The following is a description of a gene set: studied in species Mus musculus A MAPK cascade containing at least the ERK1 or ERK2 MAP kinases. It starts with the activation of a MAP3K, and the consecutive activation of a MPK2K and of ERK1 or ERK2. The cascade can also contain an additional tier: the upstream MAP4K. The kinases in each tier phosphorylate and activate the kinase in the downstream tier. The ERK1/ERK2 cascade is activated by mitogens, growth factors, G protein-coupled receptors, and results in cellular responses such as cell proliferation, cell differentiation and development. Mouse Gene Set: GOBP_ERK1_AND_ERK2_CASCADE, and this is the list of marker genes: Rasgrp1, Ptger4, Ccl19, Prkd2, Fpr2, Fbln1, Atp6v0c, Nrp1, Dab2ip, Dusp29, Havcr2, Nek10, Rap1b, Fgf1, Oxtr, Fpr-rs7, Epha7, Oprm1, Ednra, Epha2, Rgs14, Bmyc, Fpr-rs4, Tlr2, Itgb1bp1, Ccl19-ps3 (NCBI Gene Id 65959), Il1a, Pkhd1, Ext1, Dcc, App, Ntsr2, Itgav, Adora2a, Ptpn2, Ezr, Serpinf2, Abca7, Lmo3, Ripk2, Egf, Thpo, Fgfr2, Fgb, Dusp10, Zdhhc17, Xbp1, Gnai2, Nqo2, Dusp4, Ccl19-ps6, Fga, Hmgb1, Eif3a, Garem1, Ackr3, Apoe, Il6, Gpr183, Dbndd2, Tiam1, Ngf, Ccl21d, Adipoq, Grb10, Bmp2, Chrna9, Gstp3, Gcg, Cckbr, Ccn1, Tff2, Cnksr3, Ephb1, Dusp3, Ceacam1, Btn2a2, Rap1a, Dennd2b, Cav1, Ccl21e, Emilin1, Fermt2, Pten, Edn1 (endothelin 1), Bmper, Lyn, Angpt1, Ndrg2, Cntnap2, Pdgfrb, Bmp4, Marco, Tlr9, Ephb2, Hesx1, Akap12, Chrna7, Pdgfd, Agt, Nf1, Fpr-rs3, Rapgef2, Ccl19-ps1 (NCBI Gene Id 100861618), Phb2, Htr2c, Necab2, Nrxn1, Pramel7, Mapk3, Phlpp1, Wnk4, Traf7, Nherf1, Myh9, Nox4 (NADPH oxidase 4), Inhba, Cib1, Prkcz, Fpr-rs6, Styx-ps, Mt3, Pla2g2a, Glipr2, Fn1, Psca, Errfi1, Ece1, Dusp7, Csf1r, Pde8a, Abl1, Egfr, Hand2, Chi3l1, Ptpn11, L1cam, Dlg1, Ffar4, Tbc1d10c, Rps6ka6, C1ql4, Jun, Alox15, Nlrp6, Ins2, Icam1, Gpnmb, Nod2, C3, Dmd, Ctsh, Sox9, Tnfaip8l3, Fgg, Klf4, Cysltr2, Ranbp9, Casr, Ptpn1, Tpbg, Cryba1, Cflar, Npnt, Chrna10, Synj2bp (NCBI Gene Id 28115), Ccl19-ps5, Tlr4, Notch2, Slc30a10, Nlrp12, Inppl1, Ccl11, Apip, Alkal2, Scimp, Ccl19-ps4, Cd36, Ccr3, Shc1, Mfhas1, Esr2, Dnajc27, Kdr, Fgfr3, Tnfsf11, Ptpn22, Ccl21f, Kars1, Tnip1, Ddr2, Iapp, Spred3, Fshr, Phb1, Tnfrsf11a, Acta2, Mif, Spred2, Ceacam2, Ndrg4, Ccl3, Dstyk, Fgf21, Htr2a, Prxl2c, Cxcl12, Atf3, Spry1, Fgf8, Ptprc (NCBI Gene Id 19264), E130311K13Rik, Pdgfc, Pla2g5 (phospholipase A2, group V), Mir504, Fgf4, Spry2 (sprouty RTK signaling antagonist 2), Lrp1, Mturn, Arhgap8, Vegfa, Fgf23, Map2k2, Notch1, Hmgcr, Trf, Fgf10, Tgfbr3, Cavin3, Wnk2, Atp1a3, Camk2d, Pdgfb, Nrg1, Calcr, Hras, Fgf2, Crkl, Fgfr4, Ptk2b, Pdgfra, Ptpn6, Mos, Npsr1, Fgf20, Sema6a, Cd4, Flcn, Spred1, Nelfe, Itgb3, Prmt5, Or2at4, Rras (related RAS viral (r-ras) oncogene), Epor, Cxcr4, Nod1, Vrk3, Dusp1, P2ry1, Alkal1, Zfp36l1, Card9, Ccn2, Fgfbp3, Fbxw7, Epha4, Arrb1, Nodal, Slamf1, Styx, Vegfb, Tgfb1, Ccl21a, Sstr4, Pin1, Zfp36l2, Avp, Tirap, Npy5r, Ace2, Apela, Igf1, Sirt3, Cxcl17, Rapgef1, Ccr1, Ywhaz, Fgf18, Myc, Fam3c, Ramp3, Htr2b, Ros1, Gpr55, F2rl1, Clcf1, Adcyap1, Map2k7, Src, Hcrtr1, Gstp-ps, Trem2, Pde8b, Dusp15 (dual specificity phosphatase-like 15), Map2k1, Gper1, Npy (NCBI Gene Id 68398), Prkca, Gstp1, Dusp6, Ccl21b, C5ar1, Abl2, Gas6, Cd74, Sema7a, Gpbar1, Erbb2, Pdgfa, Csk, Adra1a, Iqgap3, Ntrk1, Fgf15, Nptn, Ptprr, Fbxo21, Cd44, Gcnt2, Frs2, P2ry6, Adam17 (NCBI Gene Id 236174), Trpv4, S2bpcox16, Sirpa, Ager, Map3k12, Epo, Drd2, Crhr2, Ankrd26, Smad4, Braf, Ccr1l1, Pin1rt1, Syk, Spry4, Nampt, Cd2ap, Mapk1, Il1b, Lif, Dynlt1b, Esr1, Flt4, Fam83d, Tek, Gstp2, Erbb4, Pycard, Dusp26, Rit2, Dab2, Dusp9, Arrb2, C1qtnf3, F2r